Given this list of marker genes TCIM, ADGRV1, ADISSP, AKAP12, AKAP6, here is a description of the gene set: Any process that increases the rate, frequency, or extent of protein kinase A signaling. PKA signaling is the series of reactions, mediated by the intracellular serine/threonine kinase protein kinase A, which occurs as a result of a single trigger reaction or compound. species: Homo sapiens Human Gene Set: GOBP_POSITIVE_REGULATION_OF_PROTEIN_KINASE_A_SIGNALING